Given this list of marker genes Abhd16a, Abhd12b, Abhd12, Faah, Abhd6, Abhd16b, Mgll, here is a description of the gene set: studied in species Mus musculus The chemical reactions and pathways resulting in the breakdown of monoacylglycerol, any ester of glycerol in which any one of its hydroxyl groups has been acylated with a fatty acid, the other being non-esterified. Mouse Gene Set: GOBP_MONOACYLGLYCEROL_CATABOLIC_PROCESS